Given this list of marker genes ITK, MAGT1, SYK, STAT6, BIRC3, NFATC2 (NCBI Gene Id 4773), IKZF3, FCHO1, PIK3R1, NBN, PTPRC, FASLG, ADA, DIAPH1, RASGRP1, FAS, CCND1, CASP10, BCL10, MALT1, ATM, FOXP1, here is a description of the gene set: B-cell lymphoma A type of lymphoma that originates in B-cells. Human Gene Set: HP_B_CELL_LYMPHOMA species: Homo sapiens